Given this list of marker genes KIT, here is a description of the gene set: species: Homo sapiens part of: Drug resistance of KIT mutants Reactome Pathway: Sunitinib-resistant KIT mutants Sunitinib is a class II tyrosine kinase inhibitor that is often used as a second line treatment in KIT-mutated cancers that develop resistance to imatinib.